Given this list of marker genes CDKN1B, UBB, LIN52, SKP2, LIN37, PRIM2 (DNA primase subunit 2), RPS27A, PSMD13, PSMC1, MAX, LIN9, GMNN, PPP2R1A, PSMA6, PSMB2, E2F5, TYMS, CCNB1, PSMC3, CCNA1, MCM8, AKT1, PSMD11, PSMD7, E2F4, PSMB6, SEM1, ORC5, PSMB1, AKT2, ORC4, CABLES1, RPA3, MCM7, CUL1, TFDP1, PSMD14, PSMA1, PSMC4, CCNE1, PTK6, MCM6, PSMD6, SKP1, CDK2, UBC, PSMD8, PSMB3, CCND1, PPP2R3B, RRM2, LIN54, PSMA4, MCM3, ORC2, AKT3, RBL1, E2F6, PSMD3, RPA4 (replication protein A4), CDKN1A, CKS1B (NCBI Gene Id 88475), PSMB5, MCM5, CDK1, ORC3, ADRM1, CDK7, PSMD1, PPP2CB, MNAT1, PSMD12, CDT1, CCNH, ORC1, RPA1, PSMB4, PSMA3, PPP2CA, RBBP4, PSMA7, PSMB7, UBA52, PSMC5, PCNA, ORC6, TFDP2, DHFR, WEE1, CCNA2, PSMD2, CCNE2, CDC6, PSMA2, MCM2, POLE3, CDC25A, PSMC6, POLA1, POLE, PSMC2 (NCBI Gene Id 5701), DBF4, PRIM1, MCM4, POLA2 (DNA polymerase alpha 2, accessory subunit), POLE2 (NCBI Gene Id 5427), RPA2, PPP2R1B, TK1, CDC7, RB1, PSMA5, MYC, CDK4, POLE4, HDAC1, MCM10, FBXO5, RBL2, E2F1, CDC45, here is a description of the gene set: studied in species Homo sapiens Reactome Pathway: G1/S Transition Cyclin E - Cdk2 complexes control the transition from G1 into S-phase. In this case, the binding of p21Cip1/Waf1 or p27kip1 is inhibitory. Important substrates for Cyclin E - Cdk2 complexes include proteins involved in the initiation of DNA replication. The two Cyclin E proteins are subjected to ubiquitin-dependent proteolysis, under the control of an E3 ubiquitin ligase known as the SCF. Cyclin A - Cdk2 complexes, which are also regulated by p21Cip1/Waf1 and p27kip1, are likely to be important for continued DNA synthesis, and progression into G2. An additional level of control of Cdk2 is reversible phosphorylation of Threonine-14 (T14) and Tyrosine-15 (Y15), catalyzed by the Wee1 and Myt1 kinases, and dephosphorylation by the three Cdc25 phosphatases, Cdc25A, B and C. part of: Mitotic G1 phase and G1/S transition